Given this list of marker genes Ush1c, Myo7b, Ctns, Cdhr5, Cdhr2, Tmigd1, Calml4, Anks4b, here is a description of the gene set: Mouse Gene Set: GOBP_BRUSH_BORDER_ASSEMBLY species: Mus musculus The aggregation, arrangement and bonding together of adjacent microvilli through the formation of Ca(2+)-dependent adhesion links between them, forming a brush border.